Given this list of marker genes FAM20C, PDLIM4, F7, PWWP2B, TGFBR1, XYLT1, SLC66A1, ADCY7, AMDHD2, GUSB, ADRA1A (adrenoceptor alpha 1A), GSTM1, RGS1, GCNT1, IFIT1, SLC35F5, H4C14, VWA5A, DCK, DHRS3, PLXDC1, RNH1, LDHB, CERK, SAT1, MBP, STAB1, SGK3, IFIT3, OSBPL11, NFASC, CDO1, PLXNC1, S1PR1, SKI, CTSS, EPOR, SULF2, CD109, METRNL, MMD, GNA12, PLEKHM1, MYOF, ADSS1, RNF150, FCGR1A, TYROBP, SLC9A9, BST2, HEY1, RGL2, MMP8, MSMO1, PDP1, PLD4 (phospholipase D family member 4), SAMD9L, RNF144B, CNR2, MEF2A, DAXX, PAOX, HAVCR2, VWF, HAL, PACS2, ABHD12, OXCT1, CD5L, TRIM25, CTSE, ABCG1, H3-3B, CD68, CMTM4, ATP6V1A, ATP10A (NCBI Gene Id 57194), HPRT1, VAT1, SLC6A8, LIPA, RAI1, OLFML3, EYA4, MOV10, CX3CR1, RAP2A, CYTH1, SUN2, ANKRD55, NPC2, DNMT3A, LAPTM5, COTL1, S100A13, SLC46A3, GNG2, SOCS6, LRP12, NPC1, IFIT2, PLXNA1, STX4, PTPRA, LPAR5, UBL3, HDAC5, MYLIP, HMGCS1, CLEC7A, CCND1, PTGS1, NCK2, B3GNT8, ATP1A3, TMEM184B, GPX3, SMPDL3A, JUP, ZFAND2A, UBE2L6, IL6ST, SLC22A23, RMRP, RRAGC, CD300LF, HPGDS, GLA, TRPV2, MMP12, STARD3, FMN1, RCBTB2, SLCO2B1, AHNAK, CUTA, ZDHHC14, LY86, LY6S, ARL11, ZFP36L2 (NCBI Gene Id 96706), ATP6V0D2, AKAP10, SLC29A3, MAN2B1, RSAD2, IQSEC1, PGAP1, HSD17B11, PLA2G15, FGD4, IL5, GRK3, ABCD4, FBXO32, PTPRK (NCBI Gene Id 5796), LRP1, NAV2, HEXB (hexosaminidase subunit beta), APOC1, ATP6V1B2, STOM, IDH1, ITGAV, RGS2, CEBPA, NUMA1, PKIB, WDR91, APLP2, COMMD4, ABCC3, MIR23B, SLC22A18, LGALS3BP, STAB2, IRF8, ATF3, TBC1D16, NRP1, TTYH2, PCK2, PHACTR2, here is a description of the gene set: Human Gene Set: GSE21360_NAIVE_VS_PRIMARY_MEMORY_CD8_TCELL_DN The transcriptome of naive OT-I T cells was compared to memory CD8 T cells after 1, 2, 3, or 4 infection with ovalbumin expressing Listeria monocytogenes (LM-OVA). from publication Wirth TC, Xue HH, Rai D, Sabel JT, Bair T, Harty JT, Badovinac VP (PMID 20619696) Genes down-regulated in CD8 T cells: naïve versus 1' memory. species: Homo sapiens